Given this list of marker genes POLQ, NTS, GNAQ, AGPAT3, PNPLA4, AGO1, CSRNP2, PTPRJ, MSRB3, SMCO3, HIVEP2, CENPN, NR4A3, NEK7, CENPF, AGFG1, ZMYM5, PMPCB, ZNF816, SEL1L, WDSUB1, TNPO1, PUM2, KIAA1549, FHL5, ABRAXAS1, CGGBP1 (CGG triplet repeat binding protein 1), ESCO2, RPP14, ZNF845, IL23R, PHYHIPL, CFL2, ANKRD52, ACVR1C, IFT70A, MKX, MPP7, SGIP1, LIN28B, SETD6, HNRNPR, KMT2E, PCDHGA7, TNS4, TRPS1, FYTTD1, IKZF5, IFI35, MEX3D, BBX, EMP1, EIF2S1, AAK1, FBXO8, PTCD2, BCL11B, TRIM7, RUNX2, SLITRK4, AJAP1, GATM, TUB, FLRT3, PAN2, PDE1C, CNOT7, ALDH1A2, ANO3, HOXA2, RBMS3, NR2E1, PURB, TET2, LIN7C, DERL1, IL17A, CREB3L1, CHL1, CAB39, TMEM192, ANKRD36B, UNC5C, FKBP5, SPRED2, EXOSC8 (exosome component 8), TMEFF2, TENM1, EDN1, SLC39A8, PRDM13, ZFAND1, ZNF28, CREB1, ZNF813, ABCB10, GABPA, TMEM255A, CAMTA1, GRIK2, HIPK1, GABRB2, ZNF439, TPD52L3, TMEM131, COG5, ZNF808, PSMC1, SLC44A1, RORA, CREBL2, FAXC, GPATCH11, ZNF578, SEZ6L, USP50, ARPC5, KCND2, NIPBL, PLEKHO2 (NCBI Gene Id 80301), FRMD4A, DCLK1, UBE2R2, PLXDC2, WWP1, THAP11, LRRTM3, PALLD (palladin, cytoskeletal associated protein), RNF169, MOSMO, LATS1, UBR7, ZBTB2, ZNF345, CP, ACACB, CCN2, FAM120A, PLCB4, FSCN3, EIF4G2, ANKS1B, SLC6A8, ZNF860, C1QTNF9, ITPRIPL2, ZNF468, ELOVL6, MAN1A2, ZNF600, UBE2D4, SLC35F1, GSTA2, ZNF765, ZNF761, RLIM, PGR, KLHL15, NRXN1, XIAP, MS4A4A, EDNRB, ELAVL4, XKR6, HSPB8, CRACDL, STXBP5, ZNF611, PHF20 (NCBI Gene Id 80330), FARP1, BRINP1, PPARGC1A, ZNF888, GNA13, CREBRF, FGF13, here is a description of the gene set: Human Gene Set: MIR19A_5P species: Homo sapiens Genes predicted to be targets of miRBase v22 microRNA hsa-miR-19a-5p in miRDB v6.0 with MirTarget v4 prediction scores > 80 (high confidence targets). from publication Chen Y, Wang X (PMID 31504780)